Given this list of marker genes POLR2K, NCBP1, GTF2F2, NELFCD (NCBI Gene Id 51497), NELFA, NELFE, POLR2A, NELFB, POLR2E, POLR2H, NCBP2, GTF2F1 (general transcription factor IIF subunit 1), POLR2F, POLR2D, CTDP1, POLR2B, POLR2I (NCBI Gene Id 5438), POLR2L, POLR2J, SUPT5H, POLR2C, SUPT4H1, POLR2G, here is a description of the gene set: species: Homo sapiens Reactome Pathway: Abortive elongation of HIV-1 transcript in the absence of Tat part of: HIV Transcription Elongation The details specific to HIV-1 transcription elongation are described below. In the absence of the HIV-1 Tat protein, the RNA Pol II complexes associated with the HIV-1 template are non-processive. RNA Pol II is arrested after promoter clearance by the negative transcriptional elongation factors DSIF and NELF as occurs during early elongation of endogenous templates. This arrest cannot be overcome by P-TEFb mediated phosphorylation in the absence of Tat however, and elongation aborts resulting in the accumulation of short transcripts.